The following is a description of a gene set: from publication Wacker I, Sachs M, Knaup K, Wiesener M, Weiske J, Huber O, Akçetin Z, Behrens J (PMID 19158274) Human Gene Set: WACKER_HYPOXIA_TARGETS_OF_VHL studied in species Homo sapiens The von Hippel-Lindau tumor suppressor gene (VHL) is mutated in clear cell renal cell carcinomas (RCC), leading to the activation of hypoxia-inducible factor (HIF)-mediated gene transcription. Several VHL/HIF targets, such as glycolysis, angiogenesis, cell growth, and chemotaxis of tumor cells, have been implicated in the transformed phenotype of RCC-regulating properties. Here, we show that VHL suppresses key features of cell transformation through downregulation of the HIF-dependent expression of activin B, a member of the transforming growth factor beta superfamily. Activin B expression is repressed by restoration of VHL in VHL-deficient RCC cells and upregulated by hypoxia. RCC tumor samples show increased expression of activin B compared to that in the normal kidney. VHL increases cell adhesion to the extracellular matrix, promotes cell flattening, and reduces invasiveness. These effects are completely phenocopied by RNA interference-mediated knockdown of activin B and reverted by treatment with recombinant activin B. Finally, knockdown of activin B reduces tumor growth of RCC cells in nude mice. Our data indicate that activin B is a key mediator of VHL/HIF-induced transformation in RCC. Genes down-regulated by VHL and re-expressed under hypoxia conditions in renal carcinoma cells., and this is the list of marker genes: IGFBP3, P4HA1, CP, PDK1, ADM, ENO2 (NCBI Gene Id 2026), CA9, PFKP, HK2, INHBB, CCND1, VEGFA, TGFA